The following is a description of a gene set: That part of an axon close to and including the growth cone or the axon terminus. species: Mus musculus Mouse Gene Set: GOCC_DISTAL_AXON, and this is the list of marker genes: Elk1, Sigmar1, Kif3c, Adra2a, Rapgef3, Ror1, Sirt2, Fkbp1a, Copg2, Elfn1, Fez1 (NCBI Gene Id 235180), Cplx2, Hspa8, Ywhae, Stx3, Gria3 (NCBI Gene Id 73036), Grip1, Basp1, Srsf10 (serine and arginine-rich splicing factor 10), Aqp1, Inpp5j, Sncb, Calm1, Lrrk2, Cckar, Aatk, Cad, Prkcb, Rpl26, Dixdc1, Ucn, Polg, Glul, Mapk8ip3, Hdac5, Slc8a1, Twf2, Eno2, Kcnk2, Als2, Chrm3, Hnrnpk, Pcdh9, Thy1, Trak1, Septin7, Ptprs, Chrm2 (cholinergic receptor, muscarinic 2, cardiac), Syap1, Mapt, Prnp (NCBI Gene Id 98923), Pcdhgb1, Ctnnd1, Adcyap1, Drd4, Snca, Dpysl3, Pdyn, Gap43, Cngb1, Slc17a8, Cdh8, L1cam, Oprk1, Calml3, Stmn4, Ntrk2, Clasp2, Exoc3, Ccdc120, Orai1, Brsk1 (BR serine/threonine kinase 1), Pclo, Smo, Ptch1, Th, Chrm1, Slc8a2 (solute carrier family 8 (sodium/calcium exchanger), member 2), Cnga1, Grik1, Kif21a, Exoc6, Arpc2, Exoc8, Fscn1 (NCBI Gene Id 14086), Prkn, Taok2, Timp2, Actb (NCBI Gene Id 11476), Casr, Cd2ap, Drd2, Gsk3b, Adra2c, Hcn3, Erc2, Myo1a, Grm4, Tnn, Unc5c, Grik2, Slc2a13, Unc13c, Gabrb3, Boc (NCBI Gene Id 212529), Ncs1, Katna1, Abl1, Mylk2, Cplx4, Rapgef4 (NCBI Gene Id 71744), Scn9a, Tor1a, Stmn3, Tpm3, Dlg3, Arpc5, Arhgap4, Eps8, Grin1, Tspoap1 (TSPO associated protein 1), Cdk5r2, Eno1b, Septin5, Zfyve27, Ngfr, Unc13b, Zfp804a, Klc1, Kif20b, Prex1, Csnk1e, Aak1, Ucn3, Cxadr, Npff, Nefl, Fkbp4, C9orf72, Htr7, Git1, Kif5b, Hap1, Ssh1, Arhgef7, Dynlt1c, Snap91, Git2, Amfr, Crp, Rab3a, Ang, Gnrh1, Setx, Slc1a7, Crtac1, Trak2, Usp9x, Pafah1b1, Orai2, Crhbp, Oxt, Dtnbp1, Ghrh, Kcnc4 (NCBI Gene Id 99738, potassium voltage gated channel, Shaw-related subfamily, member 4), Ccl2, P2rx3, Calb1, Dynlt1a, Trpc5, Prss12, Ilk, Pnmt, Reg1, Slc32a1, Kcnip3, Anxa5, Flrt3, Kcnab2, Fkbp15, Fscn3, Agrn, Trpv4, Adora1, Copa, Lamp5, Atcay, Dclk1, Slc4a8, Dynlt1b, Ptbp2, Nectin1, Synj2, Hsp90aa1, Glra1, Shank2, Prkcg, Ctsz, Cttn, Pnoc, Exoc4, Tubb3, Esr1, Tbc1d24, Kcna2, Ap1s1, Penk, Dicer1, Brsk2 (BR serine/threonine kinase 2), Tpbg, Ppp1r9a, Ush2a, Ndrg2, Katnb1, Rab5a, Lrig2, Pacsin1, Opn1sw, Pcsk1, Cyth2, Sirt1 (sirtuin 1), Wdr47, Tmod2, Eno1, Flna, Drd1, Slc1a1 (solute carrier family 1 (neuronal/epithelial high affinity glutamate transporter, system Xag), member 1), Grik4, Kif21b, Pgr, Lmtk2, Prkca, Ndel1, Chrm4, Cfl1, Tiam2, Itga4, P2rx4, Hcn4, Crhr2, Oprd1, Nos1, Ntsr1, Actg1, Gria2, Ppp1r2, Rtn4r, Adcy10, Disc1, Adgrl1, Grm7, P2rx2, Auts2, Htr1b, Psen1, Lrrtm1, Gprin1 (NCBI Gene Id 26913), Snx18 (NCBI Gene Id 218636), Cib1, Nrxn1, App, Atp1a3, Calm3, Dscam, Ppp1r9b (protein phosphatase 1, regulatory subunit 9B), Calb2, Prrt2, Map2, Nrp1, Rgs10, Snap25, Cacna1b, Gria4, Ptk2b, Cbl, Cpeb4, Cnr1, Ophn1, Stmn2, Kcnma1, Pak1, Cck (NCBI Gene Id 12424), Sri, Nin, Syt11, Cbarp, Map1a, Tprg1l, Cdk5r1, Gper1, Itsn1, Ppp2ca, Clcn3, Ncam1, Ngef, Frmd7, Myh10, Igf2bp1 (insulin-like growth factor 2 mRNA binding protein 1), Cplx1, Slc4a10, Tulp1, Otx2, Grin2b, Pard6a, Gad1, Stim1, Rimbp2, Gdpd5, Cobl, Iqgap1, Kcnc1, Fmr1, Itga3, Pink1, Bdnf, Fgf13, Nrsn1, Rufy3, Src, Calm2, Exoc7 (NCBI Gene Id 53413), Chrna7, Kcnc2, Slc18a3, Dgki, Dpysl2, Cdkl5, Mical1, Cyp19a1, Unc13a, Marcks, Arpc3, Scgn, Tiam1, Dcc, Septin4, Got1, Lrp2, Neo1, Dvl1, Mapk8ip1, Abitram, Tsc2, Zpr1, Hcn1 (hyperpolarization activated cyclic nucleotide gated potassium channel 1), Tshz3, Smn1, Prph, Slc18a1, Apbb1, Hnrnpr, Rasgrf1, Crmp1, Lrp1, Epha4, Tnk2, Kif5a, Cplx3, Grik5, Nmu, Kcna6, Dctn2, Syp, Whrn, Myo9a (NCBI Gene Id 319681), Dbn1, Synj1, Pebp1, Grin2a, Clu, Npcd, Sncg, Calca, Map1b, Kcnq5, Limk1, P2rx7, Palld, Cyfip1, Npy, Elavl4, Ptprz1, Slc6a3, Acap3, Slc8a3, Septin6, Kcna1, Atp6v0d1, Cdk5, Hsp90ab1, Tenm2, Bin1, Kcnc3, Blvrb, Cpeb1 (cytoplasmic polyadenylation element binding protein 1), Cdh1, Myh14, Rac3, Dcx, Pard3, Ighmbp2, Slc9a6, Amph, Dynlt1f, Mpp4, Grik3, Kcna3, Apc, Cxcr4, Ap3d1, Scn11a, Tanc1, Dnm2, Nts, Cables1, Ptprn, Trpv2, Atp5mc1, Tsc1, Itga2, Abi1, Shtn1, Ptprf, Kif5c, Syt7, Ptprn2, Dbh, Olfm1, Gpm6a, Slc18a2, Map3k12